The following is a description of a gene set: Genes with low-CpG-density promoters (LCP) bearing histone H3 trimethylation mark at K4 (H3K4me3) in neural progenitor cells (NPC). Mouse Gene Set: MIKKELSEN_NPC_LCP_WITH_H3K4ME3 species: Mus musculus We report the application of single-molecule-based sequencing technology for high-throughput profiling of histone modifications in mammalian cells. By obtaining over four billion bases of sequence from chromatin immunoprecipitated DNA, we generated genome-wide chromatin-state maps of mouse embryonic stem cells, neural progenitor cells and embryonic fibroblasts. We find that lysine 4 and lysine 27 trimethylation effectively discriminates genes that are expressed, poised for expression, or stably repressed, and therefore reflect cell state and lineage potential. Lysine 36 trimethylation marks primary coding and non-coding transcripts, facilitating gene annotation. Trimethylation of lysine 9 and lysine 20 is detected at satellite, telomeric and active long-terminal repeats, and can spread into proximal unique sequences. Lysine 4 and lysine 9 trimethylation marks imprinting control regions. Finally, we show that chromatin state can be read in an allele-specific manner by using single nucleotide polymorphisms. This study provides a framework for the application of comprehensive chromatin profiling towards characterization of diverse mammalian cell populations. from publication Mikkelsen TS, Ku M, Jaffe DB, Issac B, Lieberman E, Giannoukos G, Alvarez P, Brockman W, Kim TK, Koche RP, Lee W, Mendenhall E, O'Donovan A, Presser A, Russ C, Xie X, Meissner A, Wernig M, Jaenisch R, Nusbaum C, Lander ES, Bernstein BE (PMID 17603471), and this is the list of marker genes: Plcd4, Zscan2, Mrps21, Sardh, Ecrg4, Ptgds, Kcnip3, Iqub, Styxl2, Gpsm3, Gpd1, Serpinb8 (serine (or cysteine) peptidase inhibitor, clade B, member 8), Fabp7, Mlc1, Tns2, Masp1, Casp12, Dhrs7c, Trex1 (NCBI Gene Id 22040, three prime repair exonuclease 1), Cab39, Dapk3, Vwa5a, Cyp2j6, Mmp1b, Ampd3, Emilin1 (elastin microfibril interfacer 1), Tmem176a, Akna, Ddr1, Glmp, Gal3st4, Arhgef11, Gpr173, Sec16b, Ggnbp1, Tgm5 (NCBI Gene Id 74176), Zmym2, Pinlyp, D5Ertd579e, Plppr2, Fgd4, Glrx, Agt, Pipox, Akt3, Tmem248 (NCBI Gene Id 77960), Kif1c (NCBI Gene Id 237826), Ecm2, Cp, 6820408C15Rik, Rdh5, Fgf1, Slc25a18 (solute carrier family 25 (mitochondrial carrier), member 18), Gbp2, Camk1g, BC028528, Cyp4f13, Timp4, Trim21, Btbd17